Given this list of marker genes IL1R1, IL17RA, SCNN1B, CTSC, IL10, KLRC4, LPIN2, IL1RN, ECM1, CIB1 (calcium and integrin binding 1), IL7, IL12A, TMC8, UBAC2, MRTFA, EGFR, IFNGR1, SCNN1A, MEFV, JAK3, IL12A-AS1, STING1, HLA-B, FAS, SLC39A4, IL23R, CTSB, ADAM17 (NCBI Gene Id 6868), SCNN1G (NCBI Gene Id 6340), CARD14, PTPN6, CCR1, AP1S3, STAT4, ERAP1, TLR4, TMC6, IL36RN, LDHA, C4A, PSTPIP1, here is a description of the gene set: A small elevation of the skin containing cloudy or purulent material usually consisting of necrotic inflammatory cells. Human Gene Set: HP_PUSTULE Pustule studied in species Homo sapiens